Given this list of marker genes EPOR, C11orf21, SOD3, PMM1, UCA1, APOBEC3C, ERMAP, GYPE, YPEL4, HBE1, TMSB15A, ASIC4, MAP1A, RFESD, HBZ, ANKRD9, AHSP, MYT1, ABAT, ACHE, SLC22A4, SMIM5, ESPN, SPINT2, CYTOR (NCBI Gene Id 112597), PNPLA4, TFR2, GFI1B, PIM2, MAPKAPK3, XK, EPB42, MT1F, MT1M, SSX2IP, CRNDE, RHD, KLF1, TSPAN17, TUBB1 (tubulin beta 1 class VI), CPOX, MT1G, RAP1GAP, BEX1, PTGS1, ACSM3, MT1X (metallothionein 1X), SLC30A10, MIR4435-2HG, GRAP2, NFE2, PITX1, SPTA1, MYL4, SLC6A9, ADD2, TF, ST6GALNAC1, ALAD, ELL2, SPECC1, GYPB, CR1L, CHPT1, SLC39A8, HBQ1, C2orf88, ICAM4, SIAH2, GATA1, RHAG, MT1E, GCAT, CTSE, DHRS13 (NCBI Gene Id 147015), MTHFD2, GDF15, SLC38A5, OSBP2, ANK1, MT1H, UBAC1, TMOD1, HMBS, KEL, IQGAP2, TSPAN32, CA2, SPTB, PKLR, MAPRE3, ST8SIA1, NT5DC4, TESC, C17orf99, GNG2, HEMGN, CPED1, RIPOR3, ABCB10, PLEK2, GYPA, SCPEP1, TLCD4, RGS10, DHFR, ATP1B2, SNX22, PPP1R14C, SMIM1, MRC2, MTURN, SLC4A1, GATA5, here is a description of the gene set: studied in species Homo sapiens Primitive erythrocyte from publication He P, Lim K, Sun D, Pett JP, Jeng Q, Polanski K, Dong Z, Bolt L, Richardson L, Mamanova L, Dabrowska M, Wilbrey-Clark A, Madissoon E, Tuong ZK, Dann E, Suo C, Goh I, Yoshida M, Nikolić MZ, Janes SM, He X, Barker RA, Teichmann SA, Marioni JC, Meyer KB, Rawlins EL (PMID 36493756) Human Gene Set: HE_LIM_SUN_FETAL_LUNG_C3_PRIMITIVE_ERYTHROCYTE